The following is a description of a gene set: Human Gene Set: MIR4327 species: Homo sapiens Genes predicted to be targets of miRBase v22 microRNA hsa-miR-4327 in miRDB v6.0 with MirTarget v4 prediction scores > 80 (high confidence targets). from publication Chen Y, Wang X (PMID 31504780), and this is the list of marker genes: PCDHA4, TNFRSF10D, DOCK8-AS1, FOSL2, GABRA1, KCNJ2, KLF9, SCN2A, SOX2, OTUD1, STAG2, PCDHA5, USP31, CALCR, GRIA4, NHSL3, RAB44, CHRNE, PCDHA11, SLC17A6, PCSK5, PCDHAC1, ZNF20, TCF12, SLC37A3, CPSF6, CCL20, GRIP1, CETN2, ZNF770, CMSS1, DCAF6, KMT2E, ROBO2, SLC20A1, DDAH1, ZC3H12C, KLF7, TSHZ1, MAP3K1, SLF2, PCDHA3, TM4SF19, PCDHAC2, PCDHA6, GATAD2A, MAPK6, ATAD2, ARHGAP25, FBXO30 (F-box protein 30), YBX1, HPGD, DIAPH2, VANGL1, PCDHA2 (NCBI Gene Id 56146), PCDHA12, WDR47, PUM1, ERLIN2, ARK2C, PLXNA2, PCDHA10, PCDHA7, GPR63, CABYR, GABPA, RFX3, ORAI3, SPIN1, NAA30, GPC5, CCNY, IGF1R, GGA3, PCDHA13, CLEC4D, ABCC4, SIMC1, CNKSR2, MEF2A, HOXA3, TUB, ATOSA, ABHD13, PCDHA1, ENOX2